The following is a description of a gene set: Mouse Gene Set: GOBP_POSITIVE_REGULATION_OF_SPHINGOLIPID_BIOSYNTHETIC_PROCESS Any process that increases the rate, frequency or extent of sphingolipid biosynthesis. Sphingolipid biosynthesis is the chemical reactions and pathways resulting in the formation of sphingolipids, any of a class of lipids containing the long-chain amine diol sphingosine or a closely related base (a sphingoid). species: Mus musculus, and this is the list of marker genes: Zfp750, Sphk2 (NCBI Gene Id 97350), Prkcd (protein kinase C, delta), Ccn1, Smpd3, Pla2g6, Sirt3, Enpp7